The following is a description of a gene set: part of: ABC transporter disorders Multidrug resistance protein 3 (ATP-binding cassette sub-family B member 4, ABCB4 aka MDR3) mediates the ATP-dependent export of organic anions, phospholipids and drugs from hepatocytes into the canalicular lumen in the presence of bile salts, especially the export of phospholipids such as phosphatidylcholine (PC). Biliary phospholipids associate with bile salts and cholesterol in mixed micelles, thereby reducing the detergent activity and cytotoxicity of bile salts and preventing cholesterol crystallisation. Thus, ABCB4 plays a crucial role in bile formation and lipid homeostasis. Defects in ABCB4 result in a wide spectrum of cholestasis phenotypes, from progressive familial intrahepatic cholestasis 3 (PFIC3; MIM:602347) and intrahepatic cholestasis of pregnancy 3 (ICP3; MIM:614972) to gallbladder disease 1 (GBD1; MIM:600803). In PFIC3, the biliary phospholipid level is substantially decreased despite the presence of bile acids. Cholestasis may be caused by the toxicity of detergent bile salts that are not associated with phospholipids, leading to bile canaliculus and biliary epithelium damage. ICP3 is a reversible form of cholestasis in the third trimester of pregnancy and quickly disappears after childbearing. GBD1 is one of the major digestive diseases. Gallstones composed of cholesterol (cholelithiasis) are the common manifestations of GBD1 in western countries. Most people with gallstones remain asymptomatic throughout their lifetimes but approximately 10-50% of individuals eventually develop symptoms. Reactome Pathway: Defective ABCB4 causes PFIC3, ICP3 and GBD1 species: Homo sapiens, and this is the list of marker genes: ABCB4